Given this list of marker genes Smurf1, Stbd1, Irgq (NCBI Gene Id 210146), Gabarapl1, Tom1, here is a description of the gene set: studied in species Mus musculus Mouse Gene Set: GOBP_SUBSTRATE_LOCALIZATION_TO_AUTOPHAGOSOME The localization process by which an autophagic substrate is delivered to a forming autophagosome.